The following is a description of a gene set: Genes up-regulated in hepatocellular carcinoma (HCC) compared to normal liver samples. from publication Acevedo LG, Bieda M, Green R, Farnham PJ (PMID 18413731) There is widespread interest in efficient characterization of differences between tumor and normal samples. Here, we show an effective methodology for genome-scale characterization of tumors. Using matched normal and tumor samples from liver cancer patients, as well as non-cancer-related normal liver tissue, we first determined changes in gene expression as monitored on RNA expression arrays. We identified several hundred mRNAs that were consistently changed in the tumor samples. To characterize the mechanisms responsible for creation of the tumor-specific transcriptome, we performed chromatin immunoprecipitation on microarray experiments to assay binding of RNA polymerase II, H3me3K27, and H3me3K9 and DNA methylation in 25,000 promoter regions. These experiments identified changes in active and silenced regions of the genome in the tumor cells. Finally, we used a virtual comparative genomic hybridization method to identify copy number alterations in the tumor samples. Through comparison of RNA polymerase II binding, chromatin structure, DNA methylation, and copy number changes, we suggest that the major contributor to creation of the liver tumor transcriptome was changes in gene copy number. studied in species Homo sapiens Human Gene Set: ACEVEDO_LIVER_CANCER_UP, and this is the list of marker genes: KXD1, MRPL13, ITFG1, SNRNP40, CISD1, LYPLAL1, SLC30A10, HLF, TCN2, PTTG1IP, ZFYVE26, POTEKP, H2AX, UBE2N, RANBP6, RPN2, ZFAND1, TRIP4, HLA-B, MPV17, RSRP1, MINPP1, USB1, RBMX (RNA binding motif protein X-linked), TIPRL, FUNDC1, GPR137B, IFT25, JPT1, ERLEC1, SWAP70, BBX, GET1, CLDND1, SMARCE1, RNF26 (ring finger protein 26), ADGRF5 (NCBI Gene Id 23282), FOXC1, ARV1, CKS1B, TBCK, MPLKIP, ACBD6, UQCRH, SSR2, ZFP36L1, PKP2, GAK, MARCHF2, RPL23A, SKIC3, DPH3, C1orf54, VWF, CCT3, SNX4 (sorting nexin 4), EIF3H, GMFB, RBBP7, BFAR, RPF1, ABCB1, TYMSOS, SMAP2, ADIPOR1, IRF6, CBLB, ANXA2R, DPH5 (NCBI Gene Id 51611), PSMB8, ZSCAN18, SLCO2A1, NAGS, DISP1, TIMM10, PHAX, CYBRD1, SLC29A3, TMED5, SRP19, SPNS1 (NCBI Gene Id 83985), ZNF7, TRIP12, DHX15, UBD, FARS2, CHCHD1, PON2, PPL, DNM1P46, RPS7, SCOC, MARS1, MRPL51, RPS27A, XPOT, COMMD10, RFX5, ADAT1, COPA (COPI coat complex subunit alpha), PIAS1, TRIM22, TUT1, FBXO28, LYSMD2, RNASE1, RBBP5, IRS2, SLC30A1, DENND5A, ASPM, H2AZ1, GNPAT, TJP1, ACBD3, ZNF544, LCMT2, CDC5L, SRP54 (signal recognition particle 54), CNPY3, SH3D19, HSP90AB1, HSPB1, MARVELD2, HDAC2, SDHC, ZNF277, IFI44, PSMD2, ASXL2, LAP3, TMEM245, PRKD2, SERPINH1, MTMR6, RIMOC1, KLF13, ZFR, ACP1, NGLY1, JARID2, TRMT61B, ZNF212, OSTC, RTRAF, H2AC6, LMAN2, FAM98A, DYNLRB1, RPL13A, SLC39A8, COMMD2, XPR1, PARP1, SLC17A4, CUL9, UQCRB (ubiquinol-cytochrome c reductase binding protein), MRPS33, C6orf226, PYGB, ETNK2, HEATR1, PAQR9, MR1, PDGFRB, DHX36, AASDHPPT, LINC00467, LRRC42, F11R, CD46, PHIP (pleckstrin homology domain interacting protein), ZHX2, CPQ, CCNA2 (cyclin A2), MAFB, RPA3, METTL3, IRAK1, INIP, H2BC12, VPS26A, STRBP, RBP7, STT3B, DARS2, YTHDF2, DROSHA, RPL14, CXorf38, SNRPC (NCBI Gene Id 6631), GPBP1, CCL5, PRKCH, ESM1, PALLD, SRP72, C14orf93, MS4A7, POLR3E, F13B, LRATD2, CHTOP, NCOA6, TMEM199, SLC50A1, KHDRBS1, PDCD7, TINF2, LRRC59, CPVL, LRP11, CMC1, ANAPC13, SEMA3B, HNRNPH3, RAB4A, XYLT2, ASAP2, FRZB, C8orf33, LRP10, TMEM109, HMGB1P1 (NCBI Gene Id 90285), SOWAHA, DTL, DMTF1, TTC32, GMFG, UTP3, GOLGA4, GIMAP5, EDEM2, SPCS1, GORASP1, TUBA1A, PMF1 (NCBI Gene Id 94958), ABCB11, SHROOM3, GBP4, JKAMP, NRAS, MORF4L2, RPL23, IQGAP1, BAG3, EIF4ENIF1, PCTP, PRRC2C, BCAT2, ITPR2, JAM3, TRIM27, LCN2, SPA17, MIF4GD, CYSTM1, LSM3, GNG10, IFIT2, UBE2T, UBA6, CETN2, AP1S2, RAB18, RDX, FKBP11, HCFC1, TALDO1, NAA10, BET1, TMEM126B, TSNAX, FAM83D, KIFAP3, C1orf35, TTC27, RBX1, IPO9, HSPA1B, IARS2, SERTAD2, WSB2, LIPA, CCDC117, LPGAT1, PSMA6, PHF3 (PHD finger protein 3), ABHD5, TMEM14A, UBE2S, POLR3F, UBLCP1 (NCBI Gene Id 134510), COL4A2, ITGAV, PPP1R16A, FOCAD, DPM1, VIM, MTFR1, PRC1, POLR2J3, PMS2P5, GNAI3, HARS2, EIF1B, UTP14C, TMEM38B, GTF3C6, ANKRD49, BAIAP2L1, WDR13, ZBTB9, TFB2M, TDRD7, MRPL9, GINS2, NUP153, TMCO1, NUDCD2, BTG3, SBDS, PEX19, MFAP1 (microfibril associated protein 1), PLA2G4C, APAF1, PRRC1, CNEP1R1, H1-2, RFC4, MSANTD3, DNAJC14, PRPF18, ZXDC (ZXD family zinc finger C), ZPR1, METTL5, WDR11, STXBP6, KCNK5, ARF3, UBQLN2, SMARCC1, MPV17L, VAMP7, ELOVL5, RAC2, PIGB, TSPAN14, IL32, TAGLN2, GRN, CCDC167, CAP2, HES1, TMEM14B, PAK1, KPNB1, TEAD2, MCTS1, YEATS2, DCAF12, SLC9A6, TYMP, UBE2Q2, NUP205, AOPEP, PLS3, ACTR3, RBM6, CD93, PHLDA3, RMDN1, CNIH4, P4HA2, AVEN, DOK4, HOMEZ, SLC26A6, EPSTI1, GNG11, NRBP2, TMED7, ZSCAN16, NTPCR, MBIP, SNAPC3, GMPS, TUSC2, HERC6, DTYMK, GYPC, DNAJB1, H4C14, KATNIP, MCM4, HBP1, ANAPC10, HPF1, PIGR, CXCL10, KLF15, SLC25A14, TAF12, ISCA1, DUSP23, HLA-DRA, SLC36A1, IDI1, PPIAL4A, SRPK1, LCP1, PDIA6, RRP36, WDR26, HLA-F, CWC27, UQCC4, CES1, NFE2L2, NAT8B, SPDYE3, POLD4, PUM3 (NCBI Gene Id 9933), TRAM2, ABCB10, RPL17, ASF1A, IRX3, VPS25, HNRNPR, DNAJC19, NDUFA4L2, H2AC20, CDC20, KIDINS220, TFG, UFC1, TMED10, AMDHD1, FNDC5, ATAD1, CKS2, ACTL6A, SUB1, MED7, ALG14, NUSAP1, GNA13, CD2 (NCBI Gene Id 914), UBE3C (NCBI Gene Id 9690), SLC4A1AP, DERL1, CXCL9 (NCBI Gene Id 4283), CKLF, ZNF791, KLHDC9, CYYR1, NQO2, NCBP2, SENP2, MTSS1, MAOB, WARS1, EXOSC4, PPIC, PREPL, RAB3IP, KLHL9, PRKAB2, PIR (pirin), ZBTB33, GTPBP4, KIFBP (NCBI Gene Id 96724), ZDHHC11, ZNF581, CPE, TMEM209, ZBTB4 (zinc finger and BTB domain containing 4), CHKA, MICA, ATL2 (atlastin GTPase 2), MARCKS, LTN1, BOLA1, GTF2IRD2B, CFHR4, XXYLT1, KLHL2, PSMD14, GBP2, KRT222 (NCBI Gene Id 125113), UCK2, YRDC, YAE1, YTHDF3, PIGT (NCBI Gene Id 94004), RPL7A, RRM2B, LMBR1, FAM162A, TYMS, MICU2, CLP1, PTGES3, CFHR5, UCHL5, USP8, ORC3, TRAPPC4, CARD10, PPID, GTF2IRD2, MTPN, PPT1, NIPSNAP2, GOLT1B, ADAM15, CHMP1B, TRIM38, SAP30L (NCBI Gene Id 79685), USP34, OARD1, CCNG1, CALU, TMEM248, USP30, ABLIM3, SERPINB1, HLA-C, ACSM5, FIP1L1, RAB33B, GGCX, TBC1D2, CTCF, ENOPH1, XPO1, NOL7, NISCH, HEXD, FHIP2A, OCRL, CREBBP, PEX1, CLDN7, MAN1C1, HMGB2, DESI2, SPARCL1, HSPA14, FAM120AOS, MUC13, LLPH, KIF1C, MDC1, ZSCAN32, RBM47, CCDC91, NMD3, CYB561D2, TIMM8A, TOX4, INTS8, IGFBP7, ABHD3, CDC16, PHF23, TRIT1, BRK1 (NCBI Gene Id 55845), ATP6V0E1, DDX21, GOLPH3L, PECAM1, SMC3, ZNF329, ARL2BP, VOPP1, SSR1, SELENOF, GMNN, VPS35, YIPF4, SLC25A46, ZNF106, PTPN12, TMEM167B, ARL8B, TMEM14C, CHMP2B, B2M, KDM3B, SUMF2, THY1, FRS3, TMTC4, DHX35, TAF7, SLC33A1, PSMD6, ZNF467, IGBP1, KANSL1, SCNM1, SMNDC1, NOC3L, TSC22D2 (TSC22 domain family member 2), MGP, MFSD14B, AQP11, ATOSA, MYNN, SEPTIN11, LRRC14, TMEM183A, FNDC3B, IMPA1, PAPSS1 (3'-phosphoadenosine 5'-phosphosulfate synthase 1), NEDD8, PDE12, IMMT, GRPEL2, ROCK2, CASK, LAMTOR3, CWF19L2, ZMYM6, MET, EML2, YWHAG, SLU7, ZDHHC23, KATNB1, UBA3, ATXN1, DSN1, MBL2, SERP1, NUCB2, ARPC5, SLC17A3, CMSS1, CALML4, XRCC1, STAMBPL1, METTL25B, NFIA, GTF2H4, PSMG1, CDK12, SRXN1, UVRAG, HMGN4, SH3GL1, KIFC2, AFF4, H2AC18, SCML1, IRF9, RMI1, C7orf50, COL4A1, SIRT7, MFSD1, LIX1L, SNX2, SMARCA1, ZXDB, FKBP5, SP2 (Sp2 transcription factor), ACLY, ERGIC2, CFHR1, CCDC51, TOPBP1, SUMO2, EXOSC3, C18orf21, ATF6 (NCBI Gene Id 22926, activating transcription factor 6), SF3B6, SPPL2A, DUSP12, KLHL12, MRPL50, EAF1 (ELL associated factor 1), LARP7, ANKMY2 (NCBI Gene Id 96008), EEF1E1 (eukaryotic translation elongation factor 1 epsilon 1), PCED1A, CYP51A1 (NCBI Gene Id 1595), JCHAIN, EIF2B2, PIGC, MRPS7, IPO4, DNMT1 (DNA methyltransferase 1), TSR3, GPX7, RPLP1, USP3, WASHC5, GTF3C2, SMYD3, CHMP5, GSKIP (NCBI Gene Id 51527), CUL5, CFHR2, GLB1, EPRS1, BTN3A2, SIMC1, SLC35F6, HSPA1A, GGPS1, C7orf25, SDCBP, TSPAN8, TARBP1, SLC38A9 (NCBI Gene Id 153129), RUNDC1, PNN, COL1A1, BLVRB, TOR1AIP1, PRODH, IK, RDH14, DNAAF2, BZW2, BLVRA, C4orf33, SORT1, ELOC, KDM5B, SEPHS1, ABHD16A, RRP12, SRRD, PTBP2, CYP3A5, AHSA2P, C6orf62, PRKAB1, DHX16, KDELR2, UQCRC2, TSEN15 (tRNA splicing endonuclease subunit 15), PYCR2, RGS5, VPS8, KCTD3, DCTN4, CD74, TMEM9, ZNFX1, SEC23IP, S100A10, LCOR, TM2D1, NSMCE2, VPS45, IRAK2, USP13, RIN2, AUH, ARHGAP12, XRCC6, PTP4A1, PIEZO2, ARHGAP19, COPS4, KANK2, CKB, UBE2V2, SPARC, MKRN2, NTAN1, LIAT1, UPF3A, PIM2 (NCBI Gene Id 11040), VBP1, TAP1, ETS1, NR2C2AP, ILF2, RAMP1, SLC2A10, TXNRD1, RIC8B, DDX27, WDCP, MTX3, WIPI1, PDGFC, GSTA4, SLC35E3, COX7B, SUN1, HYOU1, GADD45GIP1, DHX29, TP53BP2, AHCTF1, PLCG1, GPC3, GPRASP2, PLGRKT, TFIP11, EIF4A3, ZCCHC9, UAP1, DYNLT3, TRMT1L, TXNL1, MIS18A, CLEC3B, RBPMS2, RPL7, NPC1, RMI2, OSGIN1, TRIM2, NCKIPSD, TESK1, COL1A2, SLC1A3, LMO2, SEC13, METTL13, OPRPN, CTSH, RNH1, APIP, AP3S1, RB1CC1, MRPS23, PLVAP, PIK3IP1, KLHL20, ANGEL2, KPNA3, NADK2, UBE2Q1, LAMB1, CDK5, PLCL2, RNASEH2A, TMT1A, H3-5, SEC11C, TOM1L1, TMEM37, PHPT1, SAR1A, RHEB, FOXQ1, PPP2R5A, LAPTM5, HIGD1A, DTWD1, CSTF2, KPNA2, LYAR, ZNF83, RTL8C, HSD17B11, BLOC1S5, NBAS, MTRFR, CENPN, HLA-E, ADPRM, BMI1, LSM1, MYRIP, APOLD1, RRP15, AURKA, S1PR1 (NCBI Gene Id 51546), PRKAR1A, GGH, GBA1, TK1, ATP6V1A, RCN2, PEX2, RGS1, FADD, GPAA1, HEY1, H2BC12L, ALG6, LANCL1, PRPF3, HGH1, NUDT16L2P, FAT1, RBM34, ENOSF1, GNG5, ARPP19, TWF2, BTAF1, STC1, LYZ, RHOBTB3 (Rho related BTB domain containing 3), LRRC8D, CHCHD3, COL3A1, CDH5, YPEL5, C1orf131, SSC4D, SHLD2, CAVIN3 (caveolae associated protein 3), UIMC1, GIMAP7, H2BC21, ABHD15, MYLIP, NDUFB5, PSMD10, PGAM4, SCYL2, MRPS28, PSME3IP1, GON7, TCFL5, WDR41, PRICKLE4, NT5E, SLC51A, DAD1, CANT1, ARMC7, FAM222B, SLC49A4, GPKOW, RSRC1, TIMM29, MRPL44, MTERF3, BPNT2, IFT74, SOX18, SDF2, TCHP, HCP5, KHDC4, RTCA (RNA 3'-terminal phosphate cyclase), DVL3, MCM3, DOCK10, SRGN, TATDN1, FABP4, IFI27, STAG2, CTSO, ACTR6, RAP2A, ZNF217, DCP2, MCFD2, NUP133, TIGD5, VAMP5, PTBP3, CIAPIN1, SELENBP1, CD9, PURA, COPB2